The following is a description of a gene set: Human Gene Set: GOBP_REGULATION_OF_ANIMAL_ORGAN_FORMATION species: Homo sapiens Any process that modulates the rate, frequency or extent of animal organ formation. Organ formation is the process pertaining to the initial formation of an organ from unspecified parts. The process begins with the specific processes that contribute to the appearance of the discrete structure, such as inductive events, and ends when the structural rudiment of the organ is recognizable, such as a condensation of mesenchymal cells into the organ rudiment., and this is the list of marker genes: DKK1, BMP2, POU5F1, WNT2B, BMP7, ROBO2, FGFR1, SHH, BMP4, FGF8, WT1, HOXC11, AR, SULF1, HOXA11, FGF10, GATA5, CTNNB1, GDNF, FGF2, SPRY1, SIX1, CITED2, MESP1, WNT5A (NCBI Gene Id 7474), FGF1, ROBO1, WNT2 (NCBI Gene Id 7472), FRS2